The following is a description of a gene set: studied in species Mus musculus Genes predicted to be targets of miRBase v22 microRNA mmu_miR_101a_3p in miRDB v6.0 with MirTarget v4 prediction scores > 80 (high confidence targets). from publication Chen Y, Wang X (PMID 31504780) Mouse Gene Set: MIR_101A_3P, and this is the list of marker genes: Klf12, Tshz3, Prkce, Has2, Stam2, Rin2, Usp40, Tia1, Kbtbd8, Asap1, Slc8a1, Mapk6, Bcl9, 6030498E09Rik (RIKEN cDNA 6030498E09 gene), Zc3h4, Eny2, Zswim6, Fos, Htra3, Zswim5, Btbd3, Nudt19, Slc25a24, Ranbp9, Sh3pxd2a, Ptgs2, Tgfbr3 (transforming growth factor, beta receptor III), Hook3, Tmem161b, Dcaf12l2, Naca, Sigmar1, Trp53inp1, Papolg, Zfp804a, Rab1a, Zbtb7c, Zfand3, Eif5a2, Ro60, Plxna2, Rab39b, Adgrf5, Tgfbr1, Nfe2l2, Phf3, Fam222a, Runx1, Iffo2, Trim63, Leprot, Togaram1, Ppp2r2a, Magi1, Zfp558 (zinc finger protein 558), Cdyl, Megf9 (multiple EGF-like-domains 9), Rap2b, Fgd6, Slc16a4, Nsd1, Nup42, Stard13, Zfp827, Lzic, Afap1, Car13, Smarca4, Gngt1, Ap1g1, Pdzd11, Ajap1, Atp5mc2, Trpc7, Fam76b, Zfp595, Ssu72, Nipa2, Sult1d1, Pals1, Rc3h2, Rasd2, Ptprj, Tfap4, Dip2b, Zfp385b, Zfp36l2, Atp1b1, Ccdc39, Map3k4, Kif2a, Ezh2, Bche (butyrylcholinesterase), Pip5k1c, Ube2a, Pbx3, Stc1, Purb, Npnt, Gab1, Purg, Cdk8, Lrrn1, Trappc8, Nid2, Ttbk2, Rbm33 (NCBI Gene Id 72420), Arid1a, Slc19a2 (solute carrier family 19 (thiamine transporter), member 2), Dr1, Csrnp1, Sel1l, Robo2, Ino80d, Abhd17c, Skint9, Pcdh18, Fryl, Prrc2c, Fzd4, Cul3, Klf6, Cmc1, Brpf1, Syncrip, Erbin, Ppfia4, Unc79, Adamtsl3, Nemp2, Tbpl1, Acvr2b, Nr6a1, Ubr7, Arhgef3, Ipo8, Ap3s1, Lrrc39, Crisp4, Slc1a1, Rarb, Rac1, Sall1, Dag1, Bend4, Fzd6, Piezo1, Mbnl1, Chek1, Atxn1l, Otud4, Selenoi, Emp2, Aqp3, Sacm1l, Trio, Mak, Adamts17, Jdp2 (NCBI Gene Id 81703, Jun dimerization protein 2), Tmem65, Ppfia1, Meis2 (NCBI Gene Id 319479), Dennd1b, Cdc14a, Zbtb41, Unc45a, Phlda1, Zfhx4, Mtcl1, Rnf38 (NCBI Gene Id 73469), Eif5, Wnk1, Bbx, Begain, Zc3h11a, Irs1, Zfp532, Rev3l, Msx1, Tnrc6b, Eya1, Gja1, Sap30l, Shisa6, Scn1a, Lfng, Ccnj (NCBI Gene Id 240665), Ermp1, Naip5, Fga, Srsf11, Smarca1, Crebrf, Qki, Abcc5, Kcna1, Camta1, Epn2, Spred1, Dnmt3a, Sgk1, Fign, Map3k9, Dmxl2, Slc39a10, Pnrc1, Rap1b, Ppp1r1c, Trim6, Il1rap, Jmy, Cebpa, Flrt2, Dipk2a, Tnrc18, Atosa, Gpd1l, Mycn, Smarcd1, Rock2, Kif5b, Sult4a1, Aebp2, Tanc2, Mark1 (NCBI Gene Id 98697), Cilk1, Inpp4b, Rfx3, Wsb1, Wdr45b, Rab5a, Tm9sf3, Cpeb3, Lrp2, Prrg1, Abhd17b, Sub1, Ero1a, Cep350, Fbn2, Pik3c2b (phosphatidylinositol-4-phosphate 3-kinase catalytic subunit type 2 beta), Ube2d1, Abhd18, Dcaf7, Brd8, Rxrb, Ubn2, Pds5b, Nrk, Or2ag2b, Etnk1 (NCBI Gene Id 97308), Mms22l, Aspn, Sh2b3, Sorcs3, Pde4a, Zfp746, Enpep, Zcchc2, Cav3, Tfpi2, Col10a1, Mtmr2, Dlg5, Kat6a, Ppp4r3b, Slc12a2, Hnrnpa0, Trp63 (transformation related protein 63), Dsc1, Mrtfb, Cxcl10, Usp47, Flrt3, Orc4, Cers2, Scn8a, Mtx3, Gclc, Stag2, Socs2, Kdm7a, Pcdh7, Cd2bp2, Cpeb2, Mob4, Phf20l1, Prkd3, Cbfa2t2, Bicd2, Arl14epl, Aplp2, Eed, Ehmt1, Cttnbp2, Tet2, Trpc4, Atxn1, Plcb1, Zeb1, Dcbld2, Atrx, B3galt1, Cdh11, Rap2c, Nek7 (NCBI Gene Id 98561), Tubgcp4, Smap1, Mbnl3, Mycs (NCBI Gene Id 17870), Lratd1, Morn4, Atg101, Adamts20, Ube2d2a, Nr1d2, Hdx, Cadm2, Has1, Afdn, Cacnb2, Pla2g7, Dstyk, Neurod1, Cdh5 (NCBI Gene Id 12562), Ebf2, Rnf111, Nlk, Fbxw7, Ankrd17, Sinhcaf, Prpf4b, Zbtb34, Zdhhc21, Nacc2, Emp1, Zbtb18, Mpzl2, Vmn1r56, App, Lcorl